Given this list of marker genes DDIT3, KRAS, POLR2J, NRL, MRTFA, AATF, PMF1, STK11, ATF2, DAPK3, CRX, ROBO1, JDP2, ZXDC, LRRFIP2, ATF4, PAWR, here is a description of the gene set: Binding to a LRR domain (leucine rich repeats) of a protein. Human Gene Set: GOMF_LRR_DOMAIN_BINDING species: Homo sapiens